Given this list of marker genes FANCD2, ERCC4, FANCC, FANCE, FANCA, here is a description of the gene set: Deficient excision of UV-induced pyrimidine dimers in DNA studied in species Homo sapiens Human Gene Set: HP_DEFICIENT_EXCISION_OF_UV_INDUCED_PYRIMIDINE_DIMERS_IN_DNA